Given this list of marker genes ADORA2A, LMCD1, CCDC59, SFTPC, DMBT1 (deleted in malignant brain tumors 1), PGA5, SFTPA2, ADGRF5, ADRA2C, ZDHHC2, SLC34A2, SLC34A1 (NCBI Gene Id 8561), GATA6, PGA4, ADRA2A, ADORA2B, SFTPA1, ABCA3, SFTPB, CSF2RA, ADA2, PGA3, SFTA3, CSF2RB, P2RY2, CKAP4, CTSH, NAPSA, SFTPD, TTF1, here is a description of the gene set: Human Gene Set: REACTOME_SURFACTANT_METABOLISM Surfactant metabolism studied in species Homo sapiens